Given this list of marker genes MFSD8, RP2, RPGRIP1, ADAR, CFHR3, NMNAT1, SLC38A8, LRAT, TMCO1, ABCA4, PRPH2, APOE, RAB28, SPATA7, HMCN1, IMPDH1, PCYT1A, CRX, IFT74, ELOVL4, CRLS1, CDH3, CNGB3, CFI, HARS1, OPN1LW, VPS13B, MMACHC, MC1R, CTNNA1, IMPG1, CFHR1, RD3, CACNA1F, TLCD3B, PROM1, RAX2, CFAP418 (cilia and flagella associated protein 418), RPE65, EFEMP1, PAX2, OCA2, CHM, MAK, LCA5, CFH, OPN1MW, here is a description of the gene set: Abnormality of macular or foveal pigmentation. Abnormality of macular pigmentation studied in species Homo sapiens Human Gene Set: HP_ABNORMALITY_OF_MACULAR_PIGMENTATION